Given this list of marker genes PRDX3, NAA50, MIR598, TLR1, RALGPS2, FNTB, EPHX1, AMPD1, SFMBT2, RAD52, CNGA1, SMAD7, IFNGR2, LEF1, ZNRF1, STING1, NAB2, PATJ, GALNT10, FOXP1, HSPD1, RAB3IP, RPL13, ELP3, RPL10A, USP28, CMAHP, SLC12A7, MYC, ADGRG5, PTPN6, NIPAL1, XKRX, DENND6A, DCAF6, CHD4, METTL8, ICE2, ST6GAL1, SH3BP5, CCDC47, TMEM41A, TREML2, RWDD3, ARL5C, RAD50, NEDD4L, CHST15, EPSTI1, CCR9, KLHDC1, CRLF3, NSG2, TRAT1, TANC1 (NCBI Gene Id 85461), ANGPTL1, ACADM, ANP32A, ACYP1, RPLP1, ACTN1, MGRN1, HDAC2, EML5, ATRNL1, ZEB1, BDH1, SCMH1, SCARNA17, CEP68 (centrosomal protein 68), PRMT3, PELI1, KLHL6, SATB1, METTL9, RPL36A, FBLN1, GGT5, SLC35A5, ANKRD55, KBTBD11, POLI, RAPGEF4, CD2AP, CEP97, RNF40, DSE, STAMBPL1, PUM2, ID3, NKX2-1, RRAS2, AP1AR, FILIP1L, FRMD8, HMBOX1, VPS26A, SLC11A2, ST8SIA1, ZNF292, SREBF2, CHTF8, NOP16, ARID4A, DKC1, CALCRL (calcitonin receptor like receptor), FAM47E, RGS10, SELL, SH3PXD2A, RGP1, IL6ST, IFT80, PMEPA1, SSBP2, SCP2, DPH5, P2RX4, SSH2, SLC6A19, DDC, STT3B, ADAMTS10, TIAL1, TNFSF8, ESRP2, GSTT2, TET1, IFRD2, IKBKE, TCF7 (transcription factor 7), GAR1, CRIPTO, GUCA2B, TGFBR3, MGA, RCN3, TOP2B, TTC3, ITGAE, RAPGEF6, COMMD8, RREB1, RNF122, SESN1, DAPL1, PIK3IP1, TDRKH, TTC27, NRROS, SELENOP (selenoprotein P), PWP2, ADAMTS17, TNRC6C, KAT2A, ART4, PLEKHM1, SLAMF6, FOXK1, GRAMD1A, RARS2, CLYBL, SELE, CCR7, GRIA3, IL7R, N4BP2, F2RL1, FAM78A, PDK1, SLCO3A1, RNF38, WDR75, here is a description of the gene set: species: Homo sapiens The gene expression profile of peripheral Foxp3+ natural regulatory T cells isolated from Foxp3/EGFP bicistronic mice was compared to that of in vitro-induced regulatory T cells and to CD4+ conventional (Foxp3-) T cells. The role of the regulatory T cell transcription factor Foxp3 in shaping the transcriptosomes of natural and induced regulatory T cells was analyzed using mice expressing a mutant FOXP3-EGFP fusion protein (Foxp3deltaEGFP). We used gene expression microarrays to examine the transcriptional programs of natural and induced regulatory T cells and the function of Foxp3 in organizing the transcriptosomes of the respective cell type from publication Haribhai D, Lin W, Edwards B, Ziegelbauer J, Salzman NH, Carlson MR, Li SH, Simpson PM, Chatila TA, Williams CB (PMID 19265124) Human Gene Set: GSE14415_FOXP3_KO_NATURAL_TREG_VS_TCONV_DN Genes down-regulated in natural T reg with non-functional FOXP3 versus T conv.